The following is a description of a gene set: Mouse Gene Set: GOBP_DEOXYRIBONUCLEOTIDE_BIOSYNTHETIC_PROCESS species: Mus musculus The chemical reactions and pathways resulting in the formation of a deoxyribonucleotide, a compound consisting of deoxyribonucleoside (a base linked to a deoxyribose sugar) esterified with a phosphate group at either the 3' or 5'-hydroxyl group of the sugar., and this is the list of marker genes: Rrm2, Cmpk1, Dhfr, Shmt2, Tyms, Dtymk, Nme3, Rrm1, Rrm2b (ribonucleotide reductase M2 B (TP53 inducible)), Dctd, Tbpl1, Nme1, Guk1, Cmpk2, Dck (deoxycytidine kinase), Shmt1, Dguok, Adk, Nme2, Dut